Given this list of marker genes MYH7, FLNC, TNNT2, ACTC1, LMNA, TNNI3, RPL3L, DOLK, KIF20A, MYPN, here is a description of the gene set: Human Gene Set: HP_INTERSTITIAL_CARDIAC_FIBROSIS A type of myocardial fibrosis characterized by excessive diffuse collagen accumulation concentrated in interstitial spaces. species: Homo sapiens Interstitial cardiac fibrosis